Given this list of marker genes TGFB1, HLA-B, KLRC1, KIR2DL4, HAVCR2, HLA-F, HLA-G, CRK, CEACAM1, TIGIT, SERPINB4, SERPINB9, PVR, HLA-E, ARRB2, NECTIN2, CLEC12B, MICA, HLA-A, LGALS9, CD96, KLRD1, NECTIN4 (nectin cell adhesion molecule 4), LILRB1, INPP5D, GRB2, here is a description of the gene set: Human Gene Set: GOBP_NEGATIVE_REGULATION_OF_NATURAL_KILLER_CELL_MEDIATED_IMMUNITY Any process that stops, prevents, or reduces the frequency, rate, or extent of natural killer cell mediated immunity. studied in species Homo sapiens